The following is a description of a gene set: Onset of disease at the age of between 1 and 5 years. Childhood onset studied in species Homo sapiens Human Gene Set: HP_CHILDHOOD_ONSET, and this is the list of marker genes: RAF1, TBC1D8B, GABRA3, TAP2, SLC6A19, CAD, RORC, LEP, UQCRH, FGG, TPM2, SNX10, CASR, LIG3, TBX18, UNG, PYROXD1, KCNH5, AICDA, SASH3, CFI, COQ6, PSMD12, SMAD4, POLA1, ATP9A, SLC32A1, FLG, GTPBP2, SLC7A14, CD19, TPRKB, PUM1, COL10A1, CTSD, LTV1, RP2, HK1, LETM1, CIB1 (calcium and integrin binding 1), SYT2, COQ8B, TICAM1, RAB33B, VWA8, AMFR, PDCD1, LAMB2, CASP2 (NCBI Gene Id 835), SGCD, TPP2, PNPLA6, TBC1D24, REL, TRAF3IP2, XPC, CLRN2, ENPP1, PANK2, WDR19, MCM6, OPA1, FRG1, TCF4, ATP13A3, ERLIN1, ANK1, MYH7, FECH, TEFM, NDUFAF2, ATM, PYGM, PUS7 (NCBI Gene Id 54517), TRAPPC11 (trafficking protein particle complex subunit 11), PRKG2, RPS29, TCHH, B4GALNT1, CRAT, ERI1, FBXO7, EIF2B5, STAT4, PIGH, NF1, GABRG2, ZNF711, SLC52A3 (solute carrier family 52 member 3), MTMR14, ACADSB, SIL1, BGN, TULP3, ATOH1, UCHL1, CILK1, NFKB1, ATP1A3 (NCBI Gene Id 95633), SRP54, CACNA1B, NR0B1, STK4, PFKM, PITPNM3, PDK3, TUBB4A, TMPRSS3, RPGRIP1, CFAP74, PIK3R1, SLC20A2, MAD1L1, PLXNA1, SVIL, KDM6A, CASQ2, KDELR2, TRAPPC10 (NCBI Gene Id 7109), CYP3A4, OCRL, AMN, NT5C3A, STN1, CLCNKB, MAP3K14, SPTAN1, AMT, ATRX, ARHGEF9, KANK2, NBEA, WWOX, GPR156, GOSR2, DNM2, CCDC78, ABHD12, FOSL2, NSD1, SYNE2, AGR2, CSF1R, GRXCR2, TRNT1, CLCN2, CC2D1A, NFIX, P3H2, CNNM2, PPA2, COQ8A, CUBN, ITPR1, AGRN, ANKS6, UFSP2, ATP7B, FANCB, EXPH5, COA7, DHX38, AQP5, HS6ST2, ATP6V0A4, EIF2B4, RPE65, CHCHD10, FRRS1L, ACADS, HCN1, SIGMAR1, INPP5K, FBXL4, RHO, PLEC, ATP6V1A, RMRP, KMT2A, WDR62, GALE, REST, VHL (von Hippel-Lindau tumor suppressor), PRDX1, DSP, FKTN, GFAP, COL27A1, GRM6, SCO2, BTD, FCGR2A, SLC24A1, MEGF10, GBA1, TACO1, TFG, FOXP2, MMAB, KCNMA1, LAMA5, MAP2K2, SYNE1, TGFBI, AHDC1, PPCS, MOCOS, SGCE, MCOLN1, PDE6G, UNC119, MAPK8IP3, CSF3R, CLDN19, UROC1, PRSS12, VAC14, ITK, STAT2, SOX11, CCDC39, EXT1, CHRNA4, SMARCA4, SAMD9, LTBP3 (latent transforming growth factor beta binding protein 3), ADAMTS19, SLC26A1, IDS, EDC3, CD55, TTC8 (NCBI Gene Id 123016), NDUFA6, VPS41, CIC, CYP2R1, DOCK11, MTX2, SLC12A6, SPG21, STXBP2, NAT8L, ZMYND10, PTRHD1, PLCG1, KCNB1 (potassium voltage-gated channel subfamily B member 1), MRPL39 (mitochondrial ribosomal protein L39), HECTD4, HYAL1, F13A1, SH3BP2, CYP7B1, POLR1A, SLC30A9, MYPN, HNRNPA2B1, POLRMT, MARS1, SPART, PRX, CHD8, DOK7, SPG11, SIN3A, USP53, ATP6V0C, JAG1, LPIN1, KERA, INSR, UBTF, LAMP2, MRPS7, POLR3B, AFG3L2, PNPLA8, DBT, HPDL, RUNX1, RBP4, AIRE, GDAP1, HAVCR2, MMUT, COQ4, CDH3, ACP5, KRT83, KCNQ5, PPP2CA, ZFYVE19, STAT3, PPP3CA, CRB1, RAX2, SCN5A, NLGN4X, ATP1A2, NDUFAF6, IKBKB, UPF3B, AFG2B, TUSC3, IL36RN, FZR1, RASGRP2, CNP, SGPL1, TRPM3, PSMB8, ARSB, TANGO2, ECM1, NFKB2, CAV1, GALC, RAB28, PITRM1, FCSK, LMBRD1, IDH3A, DARS1, PCSK1, NUBPL, TPM4, KRT14, SPARC, CBLIF, KCNA2, RDH12, TP63, TNFRSF9, AEBP1, AIFM1, ALPK3, IKZF1, IDUA, CLN8, CACNA1I, REEP2, CLCN1, FEZF1, MRE11 (MRE11 homolog, double strand break repair nuclease), PADI3, SFRP4, DPYD, NEFL, NYX, RACGAP1, MCTS1, PRKRA, HSD11B2, PLEKHM1, TENM4, ERCC6, CYP2U1, ERCC4, SLC4A4, KCNT1, EPHB2, MLIP, GNPTAB, THRB, LIPN, C3 (complement component 3), MMP14, XIAP, ACSL4, DSTYK, NUP54, SCN3A, SHARPIN, DNAH11, CFTR, TPP1, NCF2, HYDIN, KCNH2, FBLN5, RNF170, COX6A1, MAFB, MECP2, RNF220, NGF, TGFB1, LRIG2, TPM1, CLRN1, UBA5, STT3A, FGA, TBCE, SCN1A, GMPPB, RAD51, VPS16, HADHB, TRAC, SERPINB7, MTHFR, SETD1A, CPAMD8, SDHB, GBF1, ANKH, IFT140, PROM1, ABCB7 (ATP binding cassette subfamily B member 7), WT1, GEMIN5, GNB2, TRIP13, MYT1L, HABP2, DAB1, VMA21, FGB, COL17A1, F7, PPP1R13L, DNAJC30, ADGRV1, OAT, EIF2AK2, B3GALNT2, ADAM10, ASAH1, PURA, RP1, RFXANK, CXCR2, OSMR, PHKG2, ACO2, PTPRQ, PNKP, KPTN, PRPS1, OTC, TNNT2, RAP1B, DNAJC21, SNORD118, RGS9, FCHO1, ARG1, PHKA2, RNH1, MAST3, TMEM38B, EFL1, APRT, DEF6, CALM2, ADCY3, PEX16, NDST1, GNB3, PDXK, LNPK, UMOD, ORAI1, COL1A2, MFN2, LIMS2, RDH11, REEP1, F2, NDRG1, COPB2, ARL6, RRM1, CADM3, SNRPN, NUP133, POLR1C, CLPB, TNFAIP3, DTNBP1, GPNMB, NUS1, SLC38A3, PSAP, NPHP3, IL6ST, CHD2, IMPDH1, SCNN1B, SCN4B, SOX18, DNASE1L3, PMPCB (NCBI Gene Id 9512), PEX10, GLRA2, HARS1, SH2D1A, MUSK, IGKC, PLA2G6, POLR3A, PKLR, CLDN16 (claudin 16), PMM2, SLC13A3, KCNJ11, NEMF, NAXD, NRIP1, ATP2B1, FTH1 (ferritin heavy chain 1), PMP22, MAP3K20, PEX13, COL4A3, MMACHC, SLC24A4, CTNNBL1, AGTPBP1, BTK, NCF4, CYP27B1 (cytochrome P450 family 27 subfamily B member 1), MIR184, CHP1, ISCU, HMGCS2, BBS2, ALAS2, STEAP3, TACSTD2, KBTBD13, COPA, MEFV, MMP2, WNT10A, HEPACAM, IRF8, FOXE3, DNAJC3, CYB561 (cytochrome b561), SLC16A1, BFSP1 (NCBI Gene Id 631), DYNC1H1 (NCBI Gene Id 992), UNC13D, EXT2 (exostosin glycosyltransferase 2), PLAAT3, ADPRS, LRIT3 (leucine rich repeat, Ig-like and transmembrane domains 3), PI4KA, SMPX, CD164, IGHM, MACF1, RTN2, GFPT1, NSUN2, KIF3B (kinesin family member 3B, NCBI Gene Id 9371), SGSH, BICD2, HCN4, G6PD, POLE, MCM3AP, VCP, CACNA1H, IGHMBP2, BRCA1, NDUFC2, AARS2, CARMIL2, USP48, SMC3, GBA2, BBS1, ERLIN2, POLD1, NDUFA1, FLNC, SGCG, NAGLU, GJB2 (NCBI Gene Id 2706), SLC12A5, DNAJB4, NAXE, FDXR, MSMO1, RRAGD, KCNN4, DPAGT1, CEP290, HAX1, MARS2 (methionyl-tRNA synthetase 2, mitochondrial), COG3, ACTC1, RTN4IP1, RAC1, RPGR, SLC25A19, ATP2A1, GIMAP5, SLC19A2, CAPRIN1, HINT1, CRELD1, LAMA2, SYNE4, RPS26, KRT1, DGKE, GON7, FMR1, ANTXR2, SBF2, MAD2L2, IL21R, SLC34A2, TPK1, CFL2 (NCBI Gene Id 1073), PDE6B, MPZL2, IMPG2, PRKAG2, IRF2BPL, CACNG2, GLB1, BAG3, NLRP1, NFU1, PET117 (NCBI Gene Id 100303755), EXOC7, GPR101, BANF1, CWC27 (CWC27 spliceosome associated cyclophilin), SCAF4, LGI3, PKHD1, PLCE1, PUS1, CFB, IRF7, ADAR, PRDM12, DNAH1, LMNA, BAAT, CLCN7 (NCBI Gene Id 7814), EMD, RHOBTB2, WDR45, COASY, TINF2, APTX, LIG1, STAT1, CHRNE, TRPV4, PLCG2, ABCA4, JAG2, PDE6C, C1QB, NFATC2, HSPG2, GLS, OFD1, ZNF644, EDARADD, SCYL1, IRAK4, HPRT1, FGD4, SCAPER, NMNAT1, VPS13D, IL11RA (NCBI Gene Id 3590), THPO, MYRF, EMILIN1, DMD, KCNC1, ARSK, DMXL2 (Dmx like 2), C1QC, NUP85 (nucleoporin 85), RPS19, CPT1A, PHKB, KMT2D, EXTL3, CAPNS1, G6PC1, RSPH9, CCDC28B, DYM, POMT1, BCKDK, NT5C2, KCNN2, NPC2, APOLD1, CAP2, APC2, PGAP1, PCDH19, GH1, ATP11A, KLC2, ZNFX1, HMBS, RORB, CYBB, ALDH5A1, KIRREL1, SEC23B, ATP6AP1, LAGE3, TTLL5, SCN2A, COL4A1, CD46 (CD46 molecule), DNAH9, INTS11, SPTLC1, SLC39A7, SERPING1, TECPR2, KCNQ1, PEPD, AGA, RNF216, ZNF408, SEC61A1, ASPH, HDAC4 (histone deacetylase 4), SLC2A10, TK2, UNC45B (unc-45 myosin chaperone B), DIAPH1, FA2H, CPA6, COL9A2, CHRNA2, ALS2, NEK8, DBR1, NKX6-2, CRB2, SOCS1, SLC22A5, ITPR3 (NCBI Gene Id 3710), NLGN3, GK, RIPOR2, GTPBP3, ADA2, LCK, PDSS1, BRWD1, ATP5MC3, VWA1, TTC19, CACNA1S, SNAPC4, MLPH, RYR1, HMGCR, NPHS2, CARD9, ALG2, IL17RC, STX11, HGSNAT, CFAP410, SLC19A3, GJC2, POLG, CBLB, GAS2, CAPN3, KCTD17, MAG, DAAM2, SPTLC2, CCDC134, WFS1 (NCBI Gene Id 94141, wolframin ER transmembrane glycoprotein), LMNB2, NR4A2, KRT74, CACNB4, CD3E, GYG1, PLP1, CALM1, GPIHBP1, TRRAP, CISD2, DAW1, TMEM126B, CBS (NCBI Gene Id 875), FGFR1, CNGA3, RHOH, LOXL3, AP1S2 (NCBI Gene Id 8905), TUBB4B, MECR, FBN1, DZIP1L, MPV17, TRAPPC6B, CRYM, VEGFC, ATP5F1D, PIGM, NUP62, CHKA, CSTF2, WARS2, POMT2, RGS9BP, ICOSLG, UBAP1, TECRL, PNPT1, FGD1, ANO1, TMEM199, COL1A1, TBC1D2B, C19orf12, SLC9A1, BDP1, TREX1, TRIO, ABCB6, FYB1, MS4A1, STS, CPT2, GCH1, ALG10B, VRK1, CCNO, TMEM63C, MERTK, TIAM1, KIF1C, PPOX, UBAP2L, KDM5C, GATM, POC1B, FGF14, PIDD1, PIK3CD, KIF12, TMEM240, ATP2B2, EDAR, DKC1, MED23, MYO1E, CWF19L1, IFT43, CNTNAP2 (contactin associated protein 2), COA8, COL2A1, SNX14, GUCY1A1, DDB1, CYP11B1, TTN, MPIG6B, CRPPA, SLC39A4, KMT2B, MYO5B, TCF3, DAG1, CUX2, PDZD7, RRM2B, AGPAT2, TGFBR2, AXIN1, COL6A2, STX1B (syntaxin 1B), CASK, VPS37A, AP4E1, FANCC, NDP, AAAS, ICOS (inducible T cell costimulator), PDGFB, COL18A1, EMC10, GNS, GCDH, ARL6IP1, TRDN, ATR, SH3TC2, STK11, FTSJ1, ERF, MSX1, SAMHD1, GUCY2D, CDH2, STIM1, GHR, EPRS1, LACC1, RETREG1, REEP6, PLEKHG5, CHM (CHM Rab escort protein), CLIC5, FHL1, SNUPN, SCN8A, SSBP1, PNKD (PNKD metallo-beta-lactamase domain containing), LYRM7 (LYR motif containing 7), RYR2, SLC34A1, FGF13, PRPF8, GLUL, COL6A1, NLRP3, KIF14, APCDD1 (NCBI Gene Id 85500), TRAF3, SMPD1, SYT14, PDGFRB, PANK4, RIGI, FLVCR1, ELF4, DDHD2, LZTR1, CBFB, CEP78, SLC6A1, SNF8, PEX2, KRT5, CCT5, SMAD2, GNE, CA5A, NKX2-1, MTRFR, TIMM8A, IFIH1